Given this list of marker genes WLS, HACD1, ANKH, SP7, ALPL, FGFR1, here is a description of the gene set: The process in which calcium salts, mainly carbonated hydroxyapatite, are deposited into the initial acellular cementum. studied in species Homo sapiens Human Gene Set: GOBP_CEMENTUM_MINERALIZATION